The following is a description of a gene set: Human Gene Set: GOBP_REGULATION_OF_MIRNA_CATABOLIC_PROCESS studied in species Homo sapiens Any process that modulates the frequency, rate or extent of miRNA catabolic process., and this is the list of marker genes: QKI, LIN28B, MALAT1, NEAT1 (NCBI Gene Id 283131), PNPT1, XIST, DNM3OS, ZSWIM8, HOTTIP, TENT2, ZC3H12A